Given this list of marker genes TGFBRAP1, LPIN1, CD34, CCNB1IP1, IGFBP7, CDK2AP1, PON2, BCL11A, SHANK3, MMP28, ABCC1, CDK6 (NCBI Gene Id 1021), RPS15A, RBPMS (RNA binding protein, mRNA processing factor), ERG, ZNF165, NDN, NRIP1, KCTD15, GATM, TRO, CDK4, FABP5, SELENOP, KCTD3, UBTD2, MBLAC2, DPYSL3, PHACTR1, POGZ, MAP7, CALN1, BAALC, PXDN, POGLUT2, GATA2, HSPB1, DDAH1, DPPA4, ZNRF1, NT5DC2, ATP6V0A2, TUSC1, TFEC, MACROH2A1, TMEM38B (NCBI Gene Id 55151), CRHBP, PSMG1, HSPD1, AKR1C3, ITM2C, LAPTM4B, ZNF302, SLC25A27, SPOCK3, CYTL1, ETV6, CPT1A, NKAIN2, TAF1D, SMIM24, ANGPT1, CHRDL1, DST, KIT, ZNF395, TMEM200A, SCN3A, ME3, SETD9, ZNF709, ZNF618, PRMT5, SCN9A, FAM216A, HOXB3, ECPAS, PWWP3A, UHRF1, HDGFL3, STMN1, KDM5B, SSBP2, C1QTNF4, SCHIP1, OBSL1, STK3 (NCBI Gene Id 6788), DPY19L4, CTHRC1, MEGF6, PRXL2A, SAMD13, ZNF711, DPY19L2, ZBTB8A, MIR155HG, TMEM44, MCM5, DEPTOR, IGLL1, FGD5, FRMD6, ADGRA3, DOCK7, HHEX, MEIS1, PLCB1, CRIM1, ASPH, MEG3, KHDRBS3, DSG2, MPL, F2RL1, ADAT2, MYCT1, HOXA5, ITPRIPL2, AKR1A1, CMAHP, WDR49, B4GALT6, NME1, MSH5, ANKRD28, SLC39A10, FAM171B, PAM, MIR221, ABRAXAS1, DTL, TNFRSF21, COL24A1, GLIDR, RHOBTB1, CIBAR1, NPR3, RCN1, CEP170, ZNF512B, WDR91, BTBD3 (BTB domain containing 3), ANKRD6, COL5A1, SGK3, SMYD3, MYO5C, PPM1H, CRACD, SOCS2, CFH, AKT3, ZBED3, CCDC6, ARMCX2, DNMT3B, SPIN4, MYB, NASP, RDX, LRCH2, TIMM9, SRD5A3, PLCB4, TUG1, PAICS, ALG10B, ALDH1A1, MZB1, CYYR1, PSMB5, MEST, ERMP1, DAPK1, SLC9A7, TRIP6, MICU3, ENSG00000304732, DKC1, CD109, UBE2Q2P13, NEGR1, PLEKHA5, DIPK1B, TXNRD3, BEND4, CPSF3, SMARCA2, PRKACB-DT, C11orf54, DPY19L3 (dpy-19 like C-mannosyltransferase 3), CREBZF (NCBI Gene Id 58487), TMEM163, MSRB3, MRNIP-DT (NCBI Gene Id 100996419), FLVCR1, RUVBL2, ZNF521, TRIM24, TFPI, SMARCA1, VAV3, ACACA, TCAF1, PDZD2, ACSF2, MAST4, PM20D2 (NCBI Gene Id 135293), SH3BP4, HADH, CCDC171, CNKSR3, ATP2C1, TSPYL5, TCEAL4, ARHGAP22, BSPRY, F2R, HOXA9, PROM1, SLITRK4, CBX5, SNHG33, ZNF117, EOGT, PLAGL1, FAM30A, IPO11, RAB34, GNA15, HOXA10, NAP1L3, PDE1A, GUCY1A1, SERPING1, CPA3, PRDM16, MRPS27, ARMCX1, SV2A, SH3RF1, PLA2G12A (phospholipase A2 group XIIA), RXYLT1, FLT3, CDCA7, MLLT3, HOXA3, GOLIM4, TBC1D24, SLC39A8, UBR5-DT, SLC16A14, HMGCR, CRISPLD1, SLC27A2, PKD2, GALNT7, HMGA2, GNAI1, UMODL1, SOCS6, MYO18A, SPART, IQGAP2, ATP9A, TCEAL9, CHST13, ZFTA, ITGA9, FRMD4B, SMAD1, JADE3, ZMAT1, WDR17, MSI2, ISYNA1, FAM98B, RUNX2, HLF, MAP9, PGBD1, EMP1, NKX2-3, HACD1, ADGRG6, JUP, GIHCG, SCRN1, SCD, UNG, ADAM28, IPO7, PLS3, NREP (neuronal regeneration related protein), HPGDS (NCBI Gene Id 27306), SYPL1, PRDM11, PLA2G4A, QSER1, HSH2D, RAVER2, GCSH, PRDX4, LIMCH1, TANC1, PDGFC, SPINK2, BIVM, RBM10, WASF1, FAIM, SRSF3, EBPL, TNS3, AREG, PAIP1, FHL1, BEX2, PREX2, BCAT1, VWDE, IL18, ERLIN2, CBX2, here is a description of the gene set: species: Homo sapiens Genes up-regulated in CD133+ cells (hematopoietic stem cells, HSC) compared to the CD133- cells. Human cord blood (CB)-derived CD133+ cells carry characteristics of primitive hematopoietic cells and proffer an alternative for CD34+ cells in hematopoietic stem cell (HSC) transplantation. To characterize the CD133+ cell population on a genetic level, a global expression analysis of CD133+ cells was performed using oligonucleotide microarrays. CD133+ cells were purified from four fresh CB units by immunomagnetic selection. All four CD133+ samples showed significant similarity in their gene expression pattern, whereas they differed clearly from the CD133- control samples. In all, 690 transcripts were differentially expressed between CD133+ and CD133- cells. Of these, 393 were increased and 297 were decreased in CD133+ cells. The highest overexpression was noted in genes associated with metabolism, cellular physiological processes, cell communication, and development. A set of 257 transcripts expressed solely in the CD133+ cell population was identified. Colony-forming unit (CFU) assay was used to detect the clonal progeny of precursors present in the studied cell populations. The results demonstrate that CD133+ cells express primitive markers and possess clonogenic progenitor capacity. This study provides a gene expression profile for human CD133+ cells. It presents a set of genes that may be used to unravel the properties of the CD133+ cell population, assumed to be highly enriched in HSCs. from publication Jaatinen T, Hemmoranta H, Hautaniemi S, Niemi J, Nicorici D, Laine J, Yli-Harja O, Partanen J (PMID 16210406) Human Gene Set: JAATINEN_HEMATOPOIETIC_STEM_CELL_UP